Given this list of marker genes Ubl4a, Polr1a, Car5b, Psmg4, U2af1, Rars1, Ndufb2, Snrpd1, Setbp1, Mrps12, P4hb, Zfp706, Odc1, Exosc5, Gnl3, Actg1, Aprt, Nkg7 (natural killer cell group 7 sequence), Nomo1, Uba1, Mif, Eif3j1, Csf2 (NCBI Gene Id 12981), Magt1, Comtd1, Xpot, Eif3i, Exosc8 (exosome component 8), Cd47, Uck2, Ccnd3, Rbm3, Plscr1, Ndufs4, Srp72, Noa1, Muc1, Dctpp1, Surf2, Hectd1, Ncr1, Chchd4, Eif5a, Gng2, Ddx39b, Ly6a, Calr, Cnbp, Ssr1, Larp1, Picalm, Coro1c, Cct3, Rrp9, Lss, Eif4a1, Fes, Ccr5, Ybx1, Hsp90ab1, Eif1ax, Arl5a, Adss1, Erap1, Lax1, Ppia, Psma5, Wdr46, Cox7a2, Tma7, Ddx39a, Cxcr6, Nle1, Bccip, Gimap5, Gimap7, Arf1, Snrpf, Mrpl16, Eef1e1, Atp5mc1, Timm13, Uchl3, Rbm8a (NCBI Gene Id 98227), Nfs1, Snrpb, Mybbp1a, Cops6, Polr2f, Umps, Tomm20, Il2rb (interleukin 2 receptor, beta chain), Wdr75, Sdhb, Golph3, Nop56, Krtcap2, Ciao2b, Mrpl23, Tusc1, Eif1ad (eukaryotic translation initiation factor 1A domain containing), Eif4a3, Fyn, Gpr171, Tmem11, Vcp, Luc7l3, Hnrnpa2b1, Hspa5 (heat shock protein 5), Fbl, Lsm7, Serp1, Ran, Ssr3, Sumo2, Srsf9, Crem, Srsf3, Dennd4a, Pgk1, Ubap2l, Timm9, Pdcd11, Lyar, St13, Ddx27, Gcn1, Ssrp1, Abhd17b, Nifk, Utp18, Snx3, Elmo2, Gatad2a, Fundc2, Eif3c, Rap1b, Nudcd2, Tap2, Pim2, Ppa1, H3f3b, Idh3a, Txlng, Snhg12, Cct5, Pum3 (NCBI Gene Id 68885), Sec61g, Eif2s2, Tagln2, Stip1, Psme1, Mapk6, Rpf2, Arih1, Wdr36, Lsm2, Hspa8, Osbpl8, Top1, Rif1, Hdlbp, Cfl1, Prnp, Bzw1, Atp5f1d, Spcs3, Igfbp4, Emc8, Slc19a1, Abce1, Erp44, Trmt61a, Ppig, Sema4d, Bhlhe40, Anp32e, Etv6, Gtpbp4, Desi2, BC031181, Pprc1, Smc1a, Pes1, Dgkh, Furin, Zfp106, Bop1, Sytl3, Prdx1, Ccdc86, Mrps10, Tnks1bp1, Ocel1, Atp2a2, Uimc1, H13 (histocompatibility 13), Surf6, H2-T23, Alyref, Ola1, Exosc3, Ddb1, Riok1, Atic, Ndufb6 (NADH:ubiquinone oxidoreductase subunit B6), Taf10, Prag1, Uqcrq, Nolc1, Gspt1 (NCBI Gene Id 98017), Myl12a, Rnf126, Jaml, Coa8, Nop14, Eif2s1, Atp5f1b, Micall1, Wdr12, St6galnac4, Pfn1, Nip7, Plac8, Nudt5, Pam16, Fkbp15, Snu13, Cfdp1, Tle3, Canx, Jund, Ndufb4, Imp4, Polr1e, Bub3, Mien1, Rpp30, Atp5mc3, Abcg2, Mbnl2, Chchd1, Pdia6, Creld2, Il6st (interleukin 6 signal transducer), Cmas, Psmb2 (proteasome (prosome, macropain) subunit, beta type 2), Plcg2, Manf, Cope, Nap1l1, Tuba4a, Lyset, Thop1, Ebna1bp2, Selenos (selenoprotein S), Pcgf6, Fam162a, Tex2, Lars1, Tubb4b, Uxs1, Pa2g4, Pdia3, Ddx10, Snrpa, Gem, Rsl24d1, Mrpl15 (mitochondrial ribosomal protein L15), Psmd11, Psmd12, Alkbh1, Ftsj3, Dnajc11, Hsf1, Sap18, Magoh (NCBI Gene Id 17149), Ppp1r7, Chsy1, Usp25, F2rl2 (NCBI Gene Id 268688), Slamf7, Sdhd, Btg1, Pole4, Mydgf, Prps1, Cyb5b, Ube2f, Myd88, Mrpl52, Psma3 (NCBI Gene Id 19167), Hnrnpf, Runx3, Rrp7a, Selenoi, Itfg2, Pfdn2, Ascc3, Clic4, Strap, Rnh1, Atad3a, Hspe1, Ncl, Il2ra, Rpn1, Set, Pomp, Tmed5, Tmed10, Tars1, Pabpc4, Bysl, Naa15, Nup210, Trmt6, Ddx21, Eif1a, Pim1, Pcbp1, Ubald2, Hnrnpd, Tmem167, Zap70, Ormdl2, Eloc, Tbx21, Socs1, Mgat4a, Nup160, Ifitm3, Tpp2, Eif3a, Pole3, Drg1, Stx11, Lilrb4b, Npm1, Mrpl19, Timm17a, Hdgf, Gpr18, Hspd1, Mxd1, Wac, Adora2a, Ppm1h, Cct8, Flot1 (flotillin 1), Cflar, Gpr155, Tmem238, Hsp90b1, Ube2n, Snhg6, Mgat2, Uqcc2, Huwe1, Sult2b1, Ywhae, Pebp1, Tcerg1, Abracl (ABRA C-terminal like), Hnrnpa3 (heterogeneous nuclear ribonucleoprotein A3, NCBI Gene Id 69921), Mdh2, Nop58, Dcun1d5, Nop16, Hspa4, Hnrnpab, Mapre1, Crlf2, Slc16a6 (NCBI Gene Id 104681), Nars1, Rrad (Ras-related associated with diabetes), Magohb, Atp2b1, Morc2a, Pum1, Osm, Vars1, Llph, Cox7b, Smchd1, Smim7, Agfg1, Srsf2, Mat2a, Cyrib, Sfxn1, Ube2l3, Sec23b, Bola3, Mettl1, Ccnd2 (NCBI Gene Id 97325), Gadd45g, Srsf6, Stom, Ssr2, Arf6, Abhd11, Lilrb4a, Txn2, Nsun2, Socs3, Akap9 (A kinase anchor protein 9), Snrpd3, Bola2 (NCBI Gene Id 66162), Treml2, Ppid, Ifrd1, Arglu1, Ndufab1, Pde5a, Ptges3, Cd247, Timm10 (NCBI Gene Id 30059), Bzw2, Kpna6, Eif4g1, Dhps, C1qbp, Srm, Thoc2l, Fkbp1a, Ndufa12, Nrip1, Tomm40, Mrpl21, Fermt3, Zfp593, Stx7 (syntaxin 7), Eif1, Atp5pb, Cacybp, Tnfrsf1b, Ahr (aryl-hydrocarbon receptor), Slc25a5, Manbal, Psme2, Prkcq, Ptma, Gzmb, Aatf, Gps1, Gzma, Nabp1, Hnrnpdl, Hnrnpa1, Bcl3, Dgat1, Pbdc1, Ppib, Rer1, Banf1, Metrnl, Nasp, Ikzf3, Clptm1l, Eif2b3, Snx18, Ube2s, R3hdm1, Metap2, Ddx56 (DEAD box helicase 56), Bcap29, Tomm5 (translocase of outer mitochondrial membrane 5), Pgam1, Ssbp1, Spcs2, Cct2, Mak16, Klhdc4, Ppm1g, Rcc2, Ppp1r14b, Armc5, Ssb, Ybx3, Taf1d, Lman2, Ifitm1, Hnrnpu, Cebpd, F2r, Glrx5, Gar1, Prmt1, Znhit6, Hnrnpm, Btf3, Prpf38a (PRP38 pre-mRNA processing factor 38 (yeast) domain containing A), Wdr43, Agpat3, Mphosph10, Lsm6, Nmt1 (N-myristoyltransferase 1), Rexo2, Mrpl11, Prf1, Larp4, Ddost, Atf4, Bax, Nme1, Fndc3a, Pus1, Myo6 (NCBI Gene Id 60360), Dctn6, Atp6v1g1, Cox5a, Ppan, Nol11, Aurkaip1, Tuba1c, Eif5b, Psmc5, G3bp1 (G3BP stress granule assembly factor 1), Btg3, Sub1, Iscu, Fam136a, Serbp1, Sf3b3, Rrp15, Fam220a, Yrdc, Klhdc2, Mdn1, Snrpa1, Naa20, Psmc4, Naa25, Pmpca, Kars1, Acaca, Lsm4, Cox6a1, Pus7, Serpinb9, Agpat5, Sbno2, Ergic2, Cgas, Atp2b4, Scfd1, Npm3, Dph6 (diphthamine biosynthesis 6), Nop10, Ranbp1, Cd53, Emc6, Polr2l, Eprs1, Dnajb11, Cct7, Hnrnpc, Anapc15, Irf1, Eif4e, Psma7, Map3k8, Xcl1, Tsr1, Timm8a1, Rras2, Hnrnpa0, Txndc9, Sem1, P2ry14, Srsf7, Etf1, Ier3ip1, Tcp1, Cdk4, Ptpn1, Syncrip, Ube2i, Hspa9, Utp14a, Nfil3 (NCBI Gene Id 18030), Sf3a1, Tgfb1, H3f3a, Pvr, Hsp90aa1, Cox17, Slc35b1, Mrpl54, Ifng, Erh, Cycs, Anp32b, Nlrc5, Cltb, Lrrk1, Txnl4a, Dkc1, Ptpre, Ndufaf8, Eif3b, Fam133b, Exosc7, Rhoh, Rabggtb, Irf8, Tkt, Pusl1, Ppif, Sod2, Phb1, Polr3d, Hint1, Ywhaq, Psma2, Iars1, Kdelr2, Mrto4, Tmed2, Igf2r, Uqcrb, Rbm28, Cox5b, Tspan13, Pals2, Mtdh, Cysltr2 (NCBI Gene Id 70086), Cytip, Pfdn4, Noc2l, Impdh2, Fasn, Mctp2, Rsl1d1, Ssr4, Dnttip1, Rrp1b, Hopx, Lap3, Nhp2, Eif2b1, Fubp1, Ufm1, Mrpl36, Fkbp2, Cd38, Ddx18, Dimt1, Adsl, Telo2, Pno1, Gmfb, here is a description of the gene set: Cytokines mediate cell-cell communication in the immune system and represent important therapeutic targets. A myriad of studies have highlighted their central role in immune function, yet we lack a global view of the cellular responses of each immune cell type to each cytokine. To address this gap, the authors created the Immune Dictionary, a compendium of single-cell transcriptomic profiles of more than 17 immune cell types in response to each of 86 cytokines (>1,400 cytokine-cell type combinations) in mouse lymph nodes in vivo. A cytokine-centric view of the dictionary revealed that most cytokines induce highly cell-type-specific responses. For example, the inflammatory cytokine interleukin-1β induces distinct gene programmes in almost every cell type. A cell-type-centric view of the dictionary identified more than 66 cytokine-driven cellular polarization states across immune cell types, including previously uncharacterized states such as an interleukin-18-induced polyfunctional natural killer cell state. Mouse Gene Set: CUI_NK_CELL_IL12_RESPONSE_UP Genes positively differentially expressed in cell type: NK cell upon treatment with cytokine: IL-12 in mouse lymph nodes in vivo. studied in species Mus musculus from publication Cui A, Huang T, Li S, Ma A, Pérez JL, Sander C, Keskin DB, Wu CJ, Fraenkel E, Hacohen N (PMID 38057668)